Given this list of marker genes Spi1 (NCBI Gene Id 20375), Vcp, Sirt6 (NCBI Gene Id 72769), Cdk9, Pias4, Rnf4, here is a description of the gene set: Any process that stops, prevents, or reduces the frequency, rate or extent of protein localization to chromatin. Mouse Gene Set: GOBP_NEGATIVE_REGULATION_OF_PROTEIN_LOCALIZATION_TO_CHROMATIN species: Mus musculus